Given this list of marker genes Gfap, Mtor, Plag1, Vegfc, Myc (NCBI Gene Id 17869), Ntn1, Egfr, Ptk2, Ppp1cc, Slc7a5, Il6, Mecp2, Vim, Tspo, Atxn1, Nrg1, Ufl1, Myb, Prkci, E2f1, Il1b, Igf1, Etv5, Prkch, Flt1, Lta, Tnf, Kras, Lyn, Arrb2, Cysltr1, here is a description of the gene set: studied in species Mus musculus Mouse Gene Set: GOBP_POSITIVE_REGULATION_OF_GLIAL_CELL_PROLIFERATION Any process that activates or increases the rate or extent of glial cell proliferation.